Given this list of marker genes MTTP, ATAD3A, PEX12, ALG9, HSD3B7, UBE3B, DHCR7, PMM2, PNLIP, ABCA1, SAR1B, PSAP, MSMO1, FDFT1, APOB (apolipoprotein B), ALG12, FLCN, here is a description of the gene set: An decreased concentration of cholesterol in the blood. studied in species Homo sapiens Hypocholesterolemia Human Gene Set: HP_HYPOCHOLESTEROLEMIA